The following is a description of a gene set: Peripheral blood neutrophils from periodontitis patients exhibit a hyper-reactive and hyper-active phenotype (collectively termed hyper-responsivity) in terms of production of reactive oxygen species (ROS) however the molecular basis for this observation is yet to be determined. Our objectives were to identify genes differentially expressed in hyper-responsive peripheral blood neutrophils from chronic periodontitis patients relative to periodontally healthy controls and use this data to identify potential contributory pathways to the hyper-responsive neutrophil phenotype. from publication Wright HJ, Matthews JB, Chapple IL, Ling-Mountford N, Cooper PR (PMID 18832737) Genes up-regulated in neutrophils isolated from: healthy versus patients with peridontitis. Human Gene Set: GSE12484_HEALTHY_VS_PERIDONTITIS_NEUTROPHILS_UP species: Homo sapiens, and this is the list of marker genes: CYP46A1, SOX6, RASGEF1C, GNAZ, PKLR, MIR148A, TBXAS1, HOXA7, MEP1B, CRYGS, FBLN5, BCO1, USP30, IFI44, DACT1, ADAM33, PTPN3, FGF18, CD14, PACRG, PLA2G4E, TMEM69, LIPH, P2RY12, LAMC2, SERPINE1, LORICRIN, MESP1, HSPG2, RASL12, MFSD2B, CACNA1G, C14orf39, TAPT1, MFSD6L, TRIM72 (NCBI Gene Id 493829), GFRAL, SLC6A7, TMCC2, KLHL23, PLA2G1B, CADM1, RBP3 (retinol binding protein 3), CLIC3, TMEM163, MIR154, IL36RN (NCBI Gene Id 26525), MIR205, LCE3B, ENOX1, GDF6, UBALD1, HPS3, ADAMDEC1, EXTL1, CCDC159, TMEM17, SERPINB12, GSTM3, FKBP6, SSC4D (NCBI Gene Id 136853), OXTR, NPHP3, RIN1, TTC16 (tetratricopeptide repeat domain 16), RHOD, DYNLRB2, RSPH6A, GPR55, AQP5, ANAPC1 (NCBI Gene Id 64682), PLA2R1, EPHB3, SHOX2, NT5C1B, NELL1, BCL2L14, FAM110C, TMEM45B (NCBI Gene Id 120224), MIR653, B3GNT5, TEKT3, GPR27, TBC1D21, MIR541, CLDN8, GPR88 (G protein-coupled receptor 88), MDM4, PPFIA3, GATA2, AQP8, IFNG, YIPF7, HCK, CHRNB1, PNMA3, APOC4, CCDC112, CPNE5, HTR3B, ADCYAP1, CDRT4, TOMM20L, RAD52, VWA2, EPHA8, TAL1, CLEC1A, SOX2, ARHGAP29, FATE1, HSF5, TNMD, FRMD3, FTMT, DENND6B, RIMS1, PRSS27, TBXT, VAPB, PRAMENP, PPFIA4, RPRM, ZBTB16, NEO1, LTC4S, CHDH, LCAT, CSMD2, TMEM132D, GNG2, GJB1, PGA5, CEACAM5, NXPH1, CACNG1, FERD3L, SPAG11B, EGF